The following is a description of a gene set: Neighborhood of DCC Human Gene Set: MORF_DCC Neighborhood of DCC deleted in colorectal carcinoma in the MORF expression compendium studied in species Homo sapiens, and this is the list of marker genes: RFPL3S (RFPL3 antisense), LCMT2, AKAP5, RETREG1, CASQ2, IPO8, TRPC3, IRGC, RPGRIP1, HCG4, TPH1, ZNF177 (zinc finger protein 177), SMG7-AS1, COCH, DCC, HDAC9, TAF4, EIF2B1, ARK2N, GABRA6, PTPRJ, FAM13C, ORC4, EPHA7, AVPR1A, BMPR2, ODF2, IFT88, WIPF1 (NCBI Gene Id 7456), TRIM9, SPAG8, BMPER, ADGRB3, CRISP2, SLCO1B1, LRRTM2, HSD17B2, GNA12, ANGPTL7, GK2, SERPINC1, FRK, MPPED2, ZNF154, PRORP, OPHN1, RFPL1S, TBC1D12, CRISP1, LCAT, KALRN, RBM17, RFX1, MLLT3, FOXN2, GRM8, PPP6R2, ATG4B, ADAM7, ST8SIA4, DMP1 (dentin matrix acidic phosphoprotein 1), AP4E1, AKR1D1, IFNA4, BAAT, GPR4, KRT37, DFFB (DNA fragmentation factor subunit beta), ZNF264, VPS41 (NCBI Gene Id 27072), DCAF4, ART3, TTF1 (NCBI Gene Id 7270), TNFSF11, GCNT2, BRDT, AKAP4, MYH7, ATRNL1, RFXAP, CXCL6, UGT2B4 (NCBI Gene Id 7363), LCT, HOXD9, STARD13, DZIP1, TMEM8B, IFNAR1, CHRNA3, MYT1, OSGIN2, PSMD4P1, IL9, PDCL (NCBI Gene Id 51420), MTRF1L (mitochondrial translation release factor 1 like), GPR176, RPGRIP1L, SSX2IP, TCF15, ZNF10, TBC1D31, ASTN1, SLCO2A1, MINAR1, DOC2A, CST5, CBLIF, GLDC, IREB2, TNNI2, SLITRK2, CUL3